Given this list of marker genes A1CF, APOBEC3C (apolipoprotein B mRNA editing enzyme catalytic subunit 3C), APOBEC1, APOBEC3A, APOBEC2, APOBEC4 (NCBI Gene Id 403314, apolipoprotein B mRNA editing enzyme catalytic polypeptide like 4), APOBEC3B, APOBEC3H, here is a description of the gene set: part of: mRNA Editing: C to U Conversion Reactome Pathway: Formation of the Editosome species: Homo sapiens The editosome for C to U editing in mammals consist of a member of cytidine deaminase family of enzymes, apoB mRNA editig catalytic polypeptide 1 (APOBEC-1) and a complementing specificity factor (ACF) in addition to the target mRNA.